Given this list of marker genes Ccng2, Adrb3, Zfp101 (NCBI Gene Id 22643), B3galt2, Klhl24, Gm27021, Crebrf (CREB3 regulatory factor), Pik3c3, Fbxo45, Ptgfr, Abca1, Nr1d2, Gab1, Rsrp1, Six5, Hmgb2, Txnip, Tcta, Etfbkmt, Tab3, here is a description of the gene set: species: Mus musculus Mouse Gene Set: SARTIPY_NORMAL_AT_INSULIN_RESISTANCE_DN from publication Sartipy P, Loskutoff DJ (PMID 14530283) We have employed microarray technology using RNA from normal 3T3-L1 adipocytes and from 3T3-L1 adipocytes made insulin-resistant by treatment with tumor necrosis factor-alpha to identify a new class of insulin-responsive genes. These genes continued to respond normally to insulin even though the adipocytes themselves were metabolically insulin-resistant, i.e. they displayed a significantly decreased rate of insulin-stimulated glucose uptake. Approximately genes/expressed sequence tags (ESTs) were screened. Of these, genes/ESTs were identified that became insulin-resistant as expected (e.g. Socs-3, junB, and matrix metalloproteinase-11). However, genes/ESTs continued to respond normally to insulin. Although some of these genes were previously shown to be regulated by insulin (e.g. Glut-1 and beta3-adrenergic receptor), other novel insulin-sensitive genes were also identified (e.g. Egr-1, epiregulin, Fra-1, and ABCA1). Real-time reverse transcription-PCR analysis confirmed the expression patterns of several of the differentially expressed genes. One gene that remained insulin-sensitive in the insulin-resistant adipocytes is the transcription factor Egr-1. Using an antisense strategy, we show that tissue factor and macrophage colony-stimulating factor, two cardiovascular risk factors, are downstream EGR-1 target genes in the adipocyte. Taken together, these data support the hypothesis that some signaling pathways remain insulin-sensitive in metabolically insulin-resistant adipocytes. These pathways may promote abnormal gene expression in hyperinsulinemic states like obesity and type II diabetes and thus may contribute to pathologies associated with these conditions. Genes down-regulated in 3T3-L1 cells (adipocyte) by insulin which continued to respond normally to insulin in the insulin resistant cells.